The following is a description of a gene set: Mouse Gene Set: GOBP_TROPHECTODERMAL_CELL_DIFFERENTIATION The process in which a relatively unspecialized cell acquires the specialized features of a trophectoderm cell. studied in species Mus musculus, and this is the list of marker genes: Hand1, Cnot1, Sp1, Esrrb, Sp3, Srf, Sox2, Cnot2 (CCR4-NOT transcription complex, subunit 2), Cdh1, Pou5f1 (POU domain, class 5, transcription factor 1), Cul3, Nodal, Rbm46, Hopx, Foxd3, Ctr9, Eomes, Ada, Bysl (bystin-like), Tfap2c, Yap1, Cdx2, Junb, Cnot3, Cited2, Tead4